The following is a description of a gene set: Difficulty in speaking due to a physical disorder of the mouth, tongue, throat, or vocal cords. Associated with a known physical or neurological cause. Human Gene Set: HP_DYSPHONIA species: Homo sapiens Dysphonia, and this is the list of marker genes: CARS1, ZFYVE26, SYT2, TPK1, VAPB (NCBI Gene Id 9217), EDA, COL6A3, CHAT, TBK1, BAZ1B, ERCC2, TARS1, RFC2, KMT2B, B4GALNT1, VHL, NKX2-5, ANXA11 (NCBI Gene Id 311), VAMP1, CRYAB, AGRN, RET, TSPOAP1, TMEM127, FTL, RYR1, PRPH, TGM6, DNAJC30, TWNK, COL13A1, AR, ERCC3, PFN1, GTF2IRD2, SBF2 (SET binding factor 2), POLG, ELN, TMEM270, ALDH18A1, GLT8D1, NUS1, MYO9A, UNC13A, DNAJB2, NOTCH3, LRP12, ANG, TTN, SQSTM1, PI4KA, SDHAF2 (succinate dehydrogenase complex assembly factor 2), SDHD, CHCHD10, SDHA (succinate dehydrogenase complex flavoprotein subunit A), TREM2, PANK2 (NCBI Gene Id 80025), FH, ALS2, HNRNPA2B1, POLR1A, PLIN4, SDHB, MATR3, SOD1, PON3, GTF2E2, DCTN1, RNF113A, FIG4, CCNF, UBQLN2, GTF2I, AARS1 (NCBI Gene Id 16), BUD23 (NCBI Gene Id 84118), EIF4H, GNAL, BIN1, CLIP2, KCTD17, TBL2, DAO, DGUOK, METTL27, STX16, KIF1B, SIL1, MAX, KCNK9, STX1A, MFN2, PRKRA, HTRA1, NF1, MGME1, CFAP410, ATXN2, DNMT3A, NEFH, GNAS, SLC5A7, NONO, EPAS1, MPLKIP, ATP5MC3, FXN, TTC19, NCF1, SRPX2, PAX8 (NCBI Gene Id 7849), PON1, PON2, SEC31A, SLC18A3, VPS11, GTF2H5, ADGRG1, COQ2, SLC25A11, ERBB4, SDHC, TARDBP, VPS13A, HSPG2, CAPN15, NEK1, SLC25A1, RNASEH1, SNAP25, VCP, GTF2IRD1, SPEG, MDH2, HK1, DLST, NEU1, VPS37D, CYP27A1, RARS1, ACTB, TUBB4A, PPARGC1A, CHMP2B, GFAP (glial fibrillary acidic protein), ABCB7, TAF15, OPTN, HMBS, RRM2B, THAP1, ASAH1, PABPN1, LIMK1, HNRNPA1, GLE1, FKBP6, CIZ1, FUS